The following is a description of a gene set: species: Homo sapiens Human Gene Set: GOBP_HRI_MEDIATED_SIGNALING A series of reactions in which a signal is passed on to downstream proteins within the cell via HRI (also known as EIF2AK1), an intracellular protein kinase that is activated by stress signals, such as heme deficiency, oxidative stress, osmotic shock, mitochondrial dysfunction and heat shock., and this is the list of marker genes: DDIT3, EIF2AK1, OMA1, ATF4, ATAD3A, DELE1, EIF2S1